The following is a description of a gene set: Genes down-regulated in bone marrow-derived macrophages with MLL4 knockout: control versus treated with LPS for 2h. Human Gene Set: GSE30971_CTRL_VS_LPS_STIM_MACROPHAGE_WBP7_KO_2H_DN Histone methyltransferases catalyze site-specific deposition of methyl groups, enabling recruitment of transcriptional regulators. In mammals, trimethylation of lysine 4 in histone H3, a modification localized at the transcription start sites of active genes, is catalyzed by six enzymes (SET1a and SET1b, MLL1–MLL4) whose specific functions are largely unknown. By using a genomic approach, we found that in macrophages, MLL4 (also known as Wbp7) was required for the expression of Pigp, an essential component of the GPI-GlcNAc transferase, the enzyme catalyzing the first step of glycosylphosphatidylinositol (GPI) anchor synthesis. Impaired Pigp expression in Wbp7-/- macrophages abolished GPI anchor-dependent loading of proteins on the cell membrane. Consistently, loss of GPI-anchored CD14, the coreceptor for lipopolysaccharide (LPS) and other bacterial molecules, markedly attenuated LPS-triggered intracellular signals and gene expression changes. These data link a histone-modifying enzyme to a biosynthetic pathway and indicate a specialized biological role for Wbp7 in macrophage function and antimicrobial response. from publication Austenaa L, Barozzi I, Chronowska A, Termanini A, Ostuni R, Prosperini E, Stewart AF, Testa G, Natoli G (PMID 22483804) species: Homo sapiens, and this is the list of marker genes: SNRNP40, TUSC2, TACC1, PLIN2, MARVELD1, TIMM8B, VSIG4, PIN1, DDAH2, PHPT1, CD84, HEATR3, ABHD6, RAB7B, PTGFRN, FGL2, LSP1, LPCAT2, CIAO2A, IL1R2, CASS4, RNASE1, MEX3B, SRD5A3, PHKG2, A2M, UBASH3B, KIAA0513, MKNK1, DNMT1, TIMM10B, RNF5 (ring finger protein 5), FAM135A, FAM13A, GRK3, SRRT, SLCO2B1, DENND1B, APBB1IP, WDR91, SSBP4, ALCAM, NDUFA4, FOXRED1, PLA2G15, SLAMF8, SCARB2, CLEC5A, DRAM2, LST1, EVI2A, C1orf162, MACF1 (microtubule actin crosslinking factor 1), RBP7, DOCK10, TMEM218, CCDC112, MYG1, PRCP, DHRS9, RCBTB2, GAS2L3, SORD, CLEC7A, MPP1, PYCARD, APMAP, RMDN2, UBL7 (NCBI Gene Id 84993), GPN3, CAMK1, SLC35A4, TXNDC12, CD101, PARL, CD180, NCEH1, ST8SIA4, SNX24, MPV17, CMTM7, LSM12, RNF114, TMEM59, TREM2, MPC1, GALC, LGALS9, EEPD1, WDFY2, ZNF503, GPX1, SKAP2, SNX30, ZDHHC7, PLPBP, LINC00900, FCN1, LINC01127, CD300LB, VAV3, NTMT1, MFNG, PLXDC2, FPR3, UCHL3, REV3L, FILIP1L, RHOT1, CRTAP, LTA4H, RAP1GDS1, ARHGAP18, NDUFS8, OTULINL, RBPJ, AIF1, SORT1 (NCBI Gene Id 6272), ITGB5, FUCA1 (alpha-L-fucosidase 1), ARHGAP6, CAPNS2 (NCBI Gene Id 92942), DISP1, ZBTB48, UHRF1 (NCBI Gene Id 96185), PIGM (NCBI Gene Id 93183), HNRNPLL, SUCLG1, C1orf54, AVPI1, CLCN5, MERTK, IDH3G, TXNIP, VAMP8, FOS, FAM168A, C5AR2, FAM174A, FN1, ADAP2, GAL3ST4, TNFRSF11A, OLFML2B, FUCA2, VMO1 (vitelline membrane outer layer 1 homolog), DNMBP, PPT1, RNASE2, CDK19, S100A4, PON2, COMMD1, CHKA, CD36, RNF135, POLE4, CALHM2, SAMHD1, ACP5, BLVRB, UBXN11, LINC02035, H2BC12, NFXL1 (nuclear transcription factor, X-box binding like 1), LIPA, FBXO9, SLC37A2, RMND5A, AURKA, UQCC5, BCKDHA, GLUD1, HEATR5A, IMPA2, RASA1, HHEX, HSD17B10, CD1E, CHN2, NAA38, PAK1 (p21 (RAC1) activated kinase 1), DRAP1, TMEM170B, FABP4, FBP1, LSM10, RPS19BP1, CD9, EVI2B, PFKFB4, CD163, DIPK2A, RREB1, ARL5A, TMT1A, GGA2, U2AF1L4